Given this list of marker genes Cyp24a1, Vdr (vitamin D (1,25-dihydroxyvitamin D3) receptor), Gc, Pias4, here is a description of the gene set: studied in species Mus musculus electronically inferred by orthology from the curated human pathway part of: Metabolism of steroids This event has been computationally inferred from an event that has been demonstrated in another species.<p>The inference is based on the homology mapping from PANTHER. Briefly, reactions for which all involved PhysicalEntities (in input, output and catalyst) have a mapped orthologue/paralogue (for complexes at least 75% of components must have a mapping) are inferred to the other species. Reactome Pathway: Vitamin D (calciferol) metabolism